The following is a description of a gene set: Any process that increases the rate, frequency or extent of macrophage cytokine production. Macrophage cytokine production is the appearance of a chemokine due to biosynthesis or secretion following a cellular stimulus, resulting in an increase in its intracellular or extracellular levels. studied in species Homo sapiens Human Gene Set: GOBP_POSITIVE_REGULATION_OF_MACROPHAGE_CYTOKINE_PRODUCTION, and this is the list of marker genes: PLCG2, PANX1, P2RX7, GPRC5B, LAPTM5, HLA-G (NCBI Gene Id 3135), CD74, TLR3, TLR7, CD36, PYCARD, RTN4, SPON2, WNT5A, MYD88, RIPK2, SIRT1, NOD1, TICAM1, SEMA7A, CARD9, LILRB1, MAPKAPK2, TLR4